The following is a description of a gene set: studied in species Homo sapiens The cytoplasm of a muscle cell; includes the sarcoplasmic reticulum. Human Gene Set: GOCC_SARCOPLASM, and this is the list of marker genes: JPH3, JPH1, ART1, RYR3, ASPH, OPRK1, IRAG1, CALU, REEP5, CALR, DMPK, TMEM109, BCL9, RYR2, SGCD, XDH, HRC, FLNC, SCN3A (sodium voltage-gated channel alpha subunit 3), ANK3, JPH4, CASQ2, FKBP1C, TMEM38A, CACNA2D1, CHERP, NOL3, CMYA5, FKBP1B, NOS1AP, S100A1, SPOCK1 (SPARC (osteonectin), cwcv and kazal like domains proteoglycan 1), SYNE2, SERPINB5, KLHL41, CAMK2G, CACNA1S, CAMK2B (calcium/calmodulin dependent protein kinase II beta), ATP2A2, JPH2, ITPR2, MTMR12, SRI, ITPR1, SLC2A4 (solute carrier family 2 member 4), BAG5, ITPR3, SRL, ATP2A3, CAVIN4, COL6A1, P3H2, RTN2, HSP90B1, AKAP6, GSTM2, NOS1, RASD1, FKBP1A, MEF2C, GSN, HAX1, ATP2A1, FABP3, SLN, CTHRC1, CCDC78, SLC8A3, IFRD1, SERTAD1, JSRP1, ELAVL1, HK2, MRLN, AGL, FSD2, CAMK2D, PLEC, TRDN, THBS4 (NCBI Gene Id 7060), DHRS7C, ANK1, MANF, DTNBP1, PLN, MB, BAALC, TMEM38B, SLC30A7, THBS1, CASQ1, STIM1, MYH10, CLEC18B, STRIT1, RYR1, H6PD, POMT1, HABP4